The following is a description of a gene set: The progression of the mitral valve over time, from its formation to the mature structure. Mouse Gene Set: GOBP_MITRAL_VALVE_DEVELOPMENT species: Mus musculus, and this is the list of marker genes: Bmpr1a (NCBI Gene Id 68748), Adamts19, Bmpr2, Dchs1, Notch1, Acvr1, Gja5, Twist1, Naglu, Lix1l, Zfpm1, Zfpm2, Axin2, Sox4, Gata4, Efna1, Smad6